The following is a description of a gene set: studied in species Mus musculus Mouse Gene Set: GOMF_MONOATOMIC_ANION_MONOATOMIC_CATION_SYMPORTER_ACTIVITY Enables the transfer of a solute or solutes from one side of a membrane to the other according to the reaction: anion(out) + cation(out) = anion(in) + cation(in)., and this is the list of marker genes: Slc6a13, Slc5a5, Slc18a2, Slc13a1, Slc6a11, Slc22a3, Slc6a2, Slc39a14, Slc12a2, Slc12a4, Slc6a12, Slc12a7, Slc12a8, Slc18a1, Slc12a3, Slc12a6, Slc6a18, Slc6a3, Slc12a5, Slc6a8, Slc6a1, Slc12a9, Slc6a4 (solute carrier family 6 (neurotransmitter transporter, serotonin), member 4), Slc22a1, Slc12a1, Slc6a6